Given this list of marker genes NF2 (NF2, moesin-ezrin-radixin like (MERLIN) tumor suppressor), CDH23, SUFU, SMARCE1, PIK3CA, TRAF7, BRAF, MEN1, CTNNB1, AIP, PDGFB, BAP1, TERT, AKT1 (NCBI Gene Id 207), SMO, SMARCB1, here is a description of the gene set: Heteronymous hemianopia species: Homo sapiens Human Gene Set: HP_HETERONYMOUS_HEMIANOPIA